The following is a description of a gene set: Genes up-regulated in colorectal adenoma compared to normal mucosa samples. from publication Sabates-Bellver J, Van der Flier LG, de Palo M, Cattaneo E, Maake C, Rehrauer H, Laczko E, Kurowski MA, Bujnicki JM, Menigatti M, Luz J, Ranalli TV, Gomes V, Pastorelli A, Faggiani R, Anti M, Jiricny J, Clevers H, Marra G (PMID 18171984) Human Gene Set: SABATES_COLORECTAL_ADENOMA_UP studied in species Homo sapiens Colorectal cancers are believed to arise predominantly from adenomas. Although these precancerous lesions have been subjected to extensive clinical, pathologic, and molecular analyses, little is currently known about the global gene expression changes accompanying their formation. To characterize the molecular processes underlying the transformation of normal colonic epithelium, we compared the transcriptomes of 32 prospectively collected adenomas with those of normal mucosa from the same individuals. Important differences emerged not only between the expression profiles of normal and adenomatous tissues but also between those of small and large adenomas. A key feature of the transformation process was the remodeling of the Wnt pathway reflected in patent overexpression and underexpression of 78 known components of this signaling cascade. The expression of 19 Wnt targets was closely correlated with clear up-regulation of KIAA1199, whose function is currently unknown. In normal mucosa, KIAA1199 expression was confined to cells in the lower portion of intestinal crypts, where Wnt signaling is physiologically active, but it was markedly increased in all adenomas, where it was expressed in most of the epithelial cells, and in colon cancer cell lines, it was markedly reduced by inactivation of the beta-catenin/T-cell factor(s) transcription complex, the pivotal mediator of Wnt signaling. Our transcriptomic profiles of normal colonic mucosa and colorectal adenomas shed new light on the early stages of colorectal tumorigenesis and identified KIAA1199 as a novel target of the Wnt signaling pathway and a putative marker of colorectal adenomatous transformation., and this is the list of marker genes: MSX2, CST1, TRIM29, UCA1, PSAT1, DUOXA2, CCNO, MUC5AC, DEFA6, SLC6A14 (NCBI Gene Id 282807), CLDN1, SH3TC2, LCN15, ACSL6, ALDH4A1, GABRP, UGT1A7, REG4 (NCBI Gene Id 83998), NAP1L1, NMU, GALNT6 (polypeptide N-acetylgalactosaminyltransferase 6), LINC00963, KLK10, RRM2, REG1B, CDH3, S100A2, WDR72, REG3A, HYAL1, TNFRSF6B, CLDN2, TEAD4, GATA2-AS1, CXCL3, AP1S3 (NCBI Gene Id 130340), INHBA, GRHL1 (NCBI Gene Id 29841), DUOX2, PCSK1, KRT23, CBLIF, NFE2L3, EPHX4, DUSP4, GRM8, IGFBP2, REG1A, LY6G6D, ASCL2, CPS1, LRP8, MMP10, DEFA5, DSC3, SLC22A3, DSG4, CXCL2, LGR5, AZGP1, APCDD1, TGFBI, HES6, MSLN, SLC6A6, S100A11, VSNL1, IL33, PF4, CXCL11 (NCBI Gene Id 6373), FOXQ1, DPEP1, S100P, FAIM2, RNF183, ODAM, C2CD4A, DSG3, MMP7, RPL22L1, BACE2, TBX3, GPSM2, DGAT2, L1TD1, FABP6, FREM2 (FRAS1 related extracellular matrix 2), MMP3, CADPS, PTP4A3, LRRC34, ART3, SERPINA3, TACSTD2, TRIM7, SP5, TNFRSF10C, AJUBA, MSX1, MMP1, KLK11, CCL20, KRT6B, DMBT1, IL13RA2, DLGAP1-AS2, ETV4, C4BPB, CEMIP, TNS4, CHAC1, S100A8 (NCBI Gene Id 6279), SLCO1B3, CXCL1, CRNDE (NCBI Gene Id 101927480), CYP4X1, TCN1, NKD1, LRRC36, NOTUM, IRX3, CXCL8, QPCT, NQO1, BMAL2 (basic helix-loop-helix ARNT like 2), SLC7A5, SLC16A4, CHI3L1, CRIPTO, RTEL1 (regulator of telomere elongation helicase 1), KRT80, CD44, GRHL3, LPL, AXIN2, ANLN, STYXL2, LCN2, SRPX2, SBSPON